The following is a description of a gene set: Mouse Gene Set: MIR_6990_5P from publication Chen Y, Wang X (PMID 31504780) Genes predicted to be targets of miRBase v22 microRNA mmu_miR_6990_5p in miRDB v6.0 with MirTarget v4 prediction scores > 80 (high confidence targets). studied in species Mus musculus, and this is the list of marker genes: Kpna6, Mlec, Tet3, Serinc5, Crlf3, Nono, Pea15a, Slc30a10, Nat8f6, Mtcl2, Usp42, Slc25a23, Mpp1, Arhgef7, Dock5, Cadm3, Xkrx, Nlgn2, Tmub1, Ypel1, Mief1, Vsnl1, Zfp111, Rbms2, Npcd, Plxna4, Ptdss1, Cldn19, Gdnf (glial cell line derived neurotrophic factor), Cd44, Mapk9, Itpripl1, Slain2, Maf, Klhl26, Esr1, Ptpn9, Pcdh9, Arhgef19, Arih2, Ddb1, Antxr1, Nr6a1, Mprip, Glt8d2, Fam120a, Nptxr, Spock2